The following is a description of a gene set: electronically inferred by orthology from the curated human pathway Reactome Pathway: Regulation of cytoskeletal remodeling and cell spreading by IPP complex components This event has been computationally inferred from an event that has been demonstrated in another species.<p>The inference is based on the homology mapping from PANTHER. Briefly, reactions for which all involved PhysicalEntities (in input, output and catalyst) have a mapped orthologue/paralogue (for complexes at least 75% of components must have a mapping) are inferred to the other species. species: Mus musculus part of: Cell-extracellular matrix interactions, and this is the list of marker genes: Tesk1, Pxn (NCBI Gene Id 19303)